The following is a description of a gene set: Any anomaly of the vocalizing of an infant's crying, i.e.,the typically loud voice production that is accompanied by tears and agitation. Abnormal cry Human Gene Set: HP_ABNORMAL_CRY species: Homo sapiens, and this is the list of marker genes: PNPO, MPV17, KMT2D, TSPYL1, VARS1, CRYAB, ZNF699, LYRM4, IFT56, LAMA2, HACD1, ABAT, UBA1, FKTN, GFPT1, MYO9A, ATRX, SLC5A7, CHAT, VPS13B, MECP2, NDUFS8 (NADH:ubiquinone oxidoreductase core subunit S8), LAMB2, ASAH1, SYT2, ATP5F1A, VAMP1, SEMA5A, KDM6A, FIG4, RAPSN, COL13A1, COQ9, LAMA3, ALPL, PPP1R21, SCN4A, CTNND2 (NCBI Gene Id 1501), COLQ, EXOSC9, NIPBL, ASPA, SNAP25, TSHR, PEX19, TRIP4, CHRND, TPM3, SNRPN, CHRNE, AGRN, SIM1, RYR1, SLC25A1, OPA1 (NCBI Gene Id 4976), SLC18A3, MAGEL2, IGHMBP2, GGPS1, CHRNA1, FTO, ATP1A3